Given this list of marker genes ECHS1, HADH (hydroxyacyl-CoA dehydrogenase), HADHB, HADHA, ACADM, here is a description of the gene set: studied in species Homo sapiens Human Gene Set: REACTOME_BETA_OXIDATION_OF_OCTANOYL_COA_TO_HEXANOYL_COA Beta oxidation of octanoyl-CoA to hexanoyl-CoA